The following is a description of a gene set: Elongation of (very) long chain fatty acids Mouse Gene Set: WP_ELONGATION_OF_VERY_LONG_CHAIN_FATTY_ACIDS species: Mus musculus, and this is the list of marker genes: Fads2, Fads1 (NCBI Gene Id 77186), Elovl2, Elovl6, Elovl4 (NCBI Gene Id 83603), Elovl3, Scd1, Elovl1, Scd2, Scd4, Fasn, Elovl7, Scd3, Elovl5